The following is a description of a gene set: studied in species Homo sapiens Genes in the cancer module 25. Human Gene Set: MODULE_25, and this is the list of marker genes: NDUFS5, NDUFC1, NDUFB8 (NCBI Gene Id 4714), NDUFB3, NDUFS4, NDUFB5, NDUFS2, NDUFS6, UQCRB, NDUFS3, NDUFS8, NDUFV1, NDUFV2